Given this list of marker genes Lyar (NCBI Gene Id 17089), Lyn, Cd63, Lrrtm1, Clec7a, Trim9, Actn4, Ston1, Cd209b, Pla2g5, Snapin, Fes, Use1, P2rx2, Lgi3, Lpar1, Snx12, Lrrk2, Pfn2, Stxbp5, Ccr7, Tub, Hyal3, Kif5b, Egf, Ptafr, Mkln1, Mapk1, Snx3, D6Wsu163e, Gripap1, C3, Dll1, Rabgef1, Src, Arhgap21, Acsl3, Axl, Nrxn1, Rap1a, Dgkd, Cbarp, Rab3c, Pparg, Syt4, Fmr1, Necab2, Syt6 (synaptotagmin VI), Pick1, Gas6, Pip4p2, Scarb1, Nod2, Ifng, Prkn, Unc13d, Rspo1, C9orf72, Arfip1, Cd36, P2rx1, Drd2, Ms4a2, Ncdn, Lrsam1, Ehd1, Slc30a8, Pla2g6 (NCBI Gene Id 53357), Rufy4, Ston2, Dync1li1, Prtn3, Arhgap44, Colec11, Pros1, Sdcbp, Rab11a, Atp9a, Fga, Rin3, Rims1, Itgb1 (NCBI Gene Id 70812), Snx4 (NCBI Gene Id 69150), Cbl, Aak1, Sh3gl2, Mib1, Epn2, Syt1, Coro1a, Eef2k, Bcr, Septin5, Tor1a, Anxa2, Npy1r, Erc2, Chmp3, Cav3, Cnst, App, Rab37, Mtmr4, Bves, Fgr, Ehd4, Erc1, Picalm, Cacna1a, Pld1, Rnf220, Pdcd6ip, Cadps2, Angpt1, Cd84, Znrf1, Fbxo45, Lamp1, Tbc1d5, Rab7, Pcsk9, Smpd1, Atad1, Abca13, Hnrnpk, Rab21, Gas1, Vps4b, Tspan7, Rab25, Camk1d, Rims4, Mff (mitochondrial fission factor), Actg1, Sdc1, Rab31, Synj1, Nr1h2, Rph3al, Unc119, Syt8, Vsnl1, Rack1, Lgals9, Tnk2, Pot1b, H1f1, Tpcn2, Scfd1, Adipoq, Ccl2 (NCBI Gene Id 20296), Syt13, Yipf5 (NCBI Gene Id 67180), Inpp5f, Ahsg, Bicd1, Ighm, Park7, Rab3d, Scamp5, Prepl, Ankrd13b, Hmgb1, Tgm2, Lypd10, Rab4b, Syt5, P2rx7, Ubqln2, Scrn1, Itgb3, Mbl1, Stx1a, Dnm1l, Snca, Stxbp3, Arf1, Cacna1i, Syk, Abr, Atp2c1, Rap1gap, Ighg1, Rubcn, Susd4, Apln, Unc13b, Chmp2a, Stap1, Npy, Ldlrap1, Tbc1d20, Rab5b, Znrf2, Psen1, Cbll1, Rimbp2, Dab2, Arhgap1, Neu3, Cacnb4, Stx1b, Slc10a4, Rest, Fcgr1, Sytl4, Fcgr3, Sh3glb1, Fcer1g, Nlgn1, Rock1, Cplx1, Zdhhc2, Mtmr2, Mapk3, Ndrg4, Plcg2, Sorl1, Smcr8, Rab33b, Ccr2, Arap1, Ankrd13d, Fpr-rs4, Rab27a, Snx33, Itsn1, Ptpn23, Cplx4, Drd3, Sirt2, Ank3, Actn2, Prkar1b, Myo5a, Hgs, Arfgap1, Slc4a8, Fgb, Cadps, Vamp4, Ptprc, Stam, Rab3b, Snx9, Sftpa1 (NCBI Gene Id 20387), Stx18, Itgb2, Pram1, Vps28, Tamalin, Hap1, Ano6, Pclo, Vegfa, Mex3b, Rit2, Gnai2, Myh9, Gata2, Casp3, Pkdcc, Snap91, Cd14, Dvl1, Eipr1, Wdr44, Git2, Sftpd, Tbc1d4, P2ry1, Rufy1, Tulp1, Smap1 (small ArfGAP 1), Atg5, Gab2, Syt17, Lgals3, P2ry2, Appl1, Prkcb, Rab3a, Crhr1, Clu, Cacna1e, Wdr54, Rph3a, Septin1, Nedd4l, Syt15, Rap1b, Itgb2l, Pla2g4a, Prom2, Vamp1 (NCBI Gene Id 78668), Sirpa, Commd1 (NCBI Gene Id 17846), Dkk1, Arrb1, Drd4, Rint1, Rab26, Atp2a2, Il15, Htr1b, Tprg1l, Snf8, Trem2, Slamf1, Clasp2, Cln3, Rims2, Doc2b, Cask, Grik5, Atp13a2 (NCBI Gene Id 74772), Calr, Cftr, C2, Appl2 (NCBI Gene Id 216190), Baiap3, Nppa, Prkaa1, Arc, Ccl21a, Itga2, Fcnb, Spi1, Bsn, Dysf (dysferlin), Septin4, Dnm1, Actb, Ppfia2, Pou5f1, Doc2g, Vtn, Colec10, Dtnbp1, Ppp3r1, Abca2, Ccl19, Foxf1, Adora2b, Rims3 (NCBI Gene Id 279225), Hfe, Ap2b1, Wnt5a, Atxn2, Lyset, Cblb, Kcnc3, Magi2, Hamp, Adra2a, Prkca, Apoa1, Mctp1, Il2rb, Apoc3, Tcp11, Il15ra (NCBI Gene Id 98822), Dnm2, Cd160, Grem1, Sh3gl1, Napb, Ppt1, Il2rg, Sele, Rapgef1, Ankfy1, Cacna1h, Rab5a, Ntf3, Tfr2, Ppp3cc, Apoc1 (NCBI Gene Id 11812), Snap29, Sirpb1a, Cplane2 (ciliogenesis and planar polarity effector 2), Wnt7a, Abca7, Il1rapl1 (interleukin 1 receptor accessory protein-like 1), Arhgdia, Scrib, Ap2a1, Git1, Cdh13, Tsg101, Pacsin2, Wnt3a, Nckap1l, Zp3, Hip1 (NCBI Gene Id 77099), Myo5b, S100a10, Hip1r, Caly, Mical1, Ppp3ca, Cd2ap, Sv2c, Iqsec1, B2m, Efnb2, Arhgap8, Rdx (radixin), Cdk5, Doc2a, Sphk1, Gata1, Rabep1, Ptx3, Syt11, Cnn2, Syt9, Adora3, Vps11, Lrpap1, Pls3, Tgfb1, Fpr-rs3, Stxbp2, Ahi1, Dock2, Il4ra, Stx4a, Cdk5r2, Cd177, Cacna1d, Slc17a7, Flot1, Il13, Notch1, Gpr151, Fgg, Ptprj, Trf, Vamp8, Slc11a1, Hck, Rnf139, Epb41l1, Dennd10, Htr1d, Bcl2l1, Cplx3, Usp46, Bet1l, Apela, Pdpk1, Map2k1, Pacsin3, Syt3, Nsf, Ptpn1, Pacsin1, Ckap5, Hamp2, Pycard, Serpine1, Myo18a, Dgkq, Rab2b, Atg3, Sdc4, Nf2, Cacna1b, Usp7, Dnajc6, Sv2b, Fpr-rs7, Sgip1, Il4 (interleukin 4), Cyba, Alms1, Rapgef4, Cav1, Snph, Ptpn5, Pllp, Nppc, Fcgr2b, Cdc42, Vps18, P2ry4, Snap23, Hmox1, Pip5k1c, Atg7, Cspg5 (chondroitin sulfate proteoglycan 5), Rac2, Exoc2, Mdm2, Apoe, Ehd2, Lyplal1 (NCBI Gene Id 226791), Ighg2b, Akap5, Siglece (NCBI Gene Id 83382), Syt10, Dlg4, Rab3gap1, Clasp1, Stxbp5l, Alox15, Pten, Ap1g1, Ophn1, Syn1, Tsc2, Rab5c, Fpr-rs6, Letmd1, Kif3a, Gsg1l, Bin1, Vamp2, Sphk2, Rab9, Rab11b, Prrt2, Braf, Hpca, Sod1, Synj2bp, Ankrd13a, Ceacam1, Cd151 (CD151 antigen), Prkcg, Ccdc32, Itgav, Plscr1, Rab29, Dnajc5, Pld2, Apoc2l (apolipoprotein C2 like), Vps4a, Rab11fip3, Msn, Bmp2k (NCBI Gene Id 71114), Apoc2, Wasl, Btk (Bruton agammaglobulinemia tyrosine kinase), Rab27b, Ager, Cdk5r1, Arrb2, Rala, Anxa1, Lypla1, Mbl2, Rnf216, Dcx, Ankrd27, Btbd9, Syt2, Clip3, Pla2g4e, Lrp1, Syt12, F2rl1, Cplx2, Hspa8, Ppp3cb, Sfrp4, Pard3, Gpc3, Ap2m1, Lrp2 (NCBI Gene Id 99378), Aplnr, Fbxl20, Pla2g3, Nrg1, Ush1g, Epha3, Fcer1a, Plk2, Cd300lf, Exph5, Nr1h3, Add1 (adducin 1), Siglecf, Lrrtm2, Apoa2, Arpc3, Kcnb1, Wdr41, C2cd5, Fpr2, Rac1, Rab4a, Dnajc13, Ezr, Mbtps1, Amph, Smpd3, Cxadr, Kcnh1, Lypd11, Lman2, Il13ra2, Vac14, Tlr2, Syt7, Ncs1, Pgap1, Cd47, Map2k2, Mertk (NCBI Gene Id 17289), Itgam, Numb, Cacna1g, Insr, Csk, Nedd4, Rab15, Sh3gl3, Cfp, Stxbp1, Lbp, Cd22, Cd300a, Ptk2, here is a description of the gene set: Any process that modulates the rate, frequency, or extent of vesicle-mediated transport, the directed movement of substances, either within a vesicle or in the vesicle membrane, into, out of or within a cell. species: Mus musculus Mouse Gene Set: GOBP_REGULATION_OF_VESICLE_MEDIATED_TRANSPORT